The following is a description of a gene set: part of: Response of Mtb to phagocytosis When the phagosomal membrane is injured, this is sensed and acted upon both by the host phagocyte and Mtb. While the host repair system is activated, the bacterium is secreting proteins that block host repair components, effectively inhibiting repair. studied in species Homo sapiens Reactome Pathway: Inhibition of membrane repair, and this is the list of marker genes: esxG, esxH, HGS